Given this list of marker genes IL17A, PDE4B, LBP (NCBI Gene Id 3929), MOSPD2, PRTN3, CCL24, CSF1, NCKAP1L, ADAM8, S100A9, RARRES2, C5AR1, CCL21, MSTN, PF4V1, GP2, DPP4, DNM1L, CXCL3, CXCR1, SLIT2, IRAK4, EDN3, CXCL5, RAC2, DAPK2, FAM3D, VAV1, TNFAIP6, CD99, EPX (eosinophil peroxidase), CCL8, CCL27, TNFSF18, MIR223, MPP1, PIK3CD, ITGB2, C5AR2, TIRAP, DPEP1 (dipeptidase 1, NCBI Gene Id 1800), SRP54, CCL25, IL17RA, CCL22, C1QBP, FUT4, CD300A, RIPOR2, IL34, PPIB, CXCL17, CSF3R, PECAM1, CCR7, CCL3, PREX1, CCL16, CXCL13, CX3CL1, C3AR1, CCL2, AKIRIN1, MCOLN2, CCL13, IL17RC, PPBP, CCL19, S100A14, PERP, EDN1, RAC3, ANXA1, PIKFYVE, PLA2G1B, PTK2, JAML, CD74, BST1, CCL4, RTN4, CXADR, TGFB2, MAPK3, CXCL9, ITGA1, ADGRE2, XCL1, PTPRJ, CCL11, CCL1, MCU, SCG2, S100A7, SAA1, S100A12, XG, ITGA9, SYK, PIP5K1C, VEGFA, CD99L2, CCL28, CCL4L2, SELENOK, PIK3CG, IL23A, CD177, CKLF, MYD88, SLAMF1, THBS1, IL1R1, LGALS3, UMOD, EDN2, CXCL10, JAGN1, MAPK1, BSG, CCL26, CXCR2, JAM3, S100A8, WDR1, CXCL8, PPIA, MDK, CAMK1D, THBS4, TRPV4, FCER1G, RAC1, EMP2, CSF1R, PF4, CCL5, PTGER4, VAV3, SLAMF8, IL1B, CD300H, CXCL6, FUT7, GBF1, CCL7, TREM1, CMKLR1, here is a description of the gene set: The movement of a granulocyte within or between different tissues and organs of the body. studied in species Homo sapiens Human Gene Set: GOBP_GRANULOCYTE_MIGRATION